Given this list of marker genes ABCC8, CDC73, IFNA14, KRR1, ATF2, GPLD1, CPB2, LORICRIN (loricrin cornified envelope precursor protein), FBXL4, PDE10A, CADM4, ZNF134, FZD5, SCN7A, GUCY2C, LTBP4, BCL2L11, PDE6A, BMP10, MASP2, CEP162 (NCBI Gene Id 22832), HTR1E, SYT5, MAP2, ZNF200, TANC2, PAX7, MON2, CCR3, NOS2 (nitric oxide synthase 2), EDIL3, PCM1, ZNF157, MLLT10, POLR1HASP, ATP8B1, GCM1, PART1, FSHR, TFDP2, P2RY10, KCNA5, KLRC4, KRT33A, PLPPR4, PHOX2B, NFAT5, PAX9, SLC4A3, EXOC4, TTTY1, KNG1, GLRA3, ERC2-IT1, ZP2, OCM, SIRPB1, S100A5, ATP4B, ZNF266, AQP7, IL7, KRT2, NRTN, CFH, RYR3, ABCB10, EPHB2, COLGALT2, ZSCAN26, GPR18, MYH2, GNG4, RUNX2, GPR19, FAS, GJB5, DMD, ADAM20, AOC4P, DNAJC16, SIM2, CRHR1, C1orf216, PVR, SLC15A1, MC5R, DRC3, TBX19, PTPRB, ZNF821, TMEM26, H3C6, GPR171, RORB, CAMK4, HNF1A, POLR2K, ABO, GLE1, DBT, PHLDB1, CXCL5, TENM4, RPS6KA5, RNF24 (NCBI Gene Id 51262), FGF18, POU6F2, CCL16, AMOT, PAXIP1, BRCA1, R3HCC1L, SLC17A3, SRPK3, SULT4A1, SLC4A8, IL11RA, DGCR5 (NCBI Gene Id 85356), PDE4D, RB1CC1, USP46, POU6F1, TBXT, COX6A2, ATP6V0A2, OR2B6, RREB1, PGM3, NR3C2, ERCC4, NTNG2, PSG1, ATXN3, AMMECR1, PCDHB17P, SIX6, ELAVL2, ATP2B2, ADAMTSL3, LECT2, MDM2, ARL3, RAD51D, TRIM24, TSSK2, STAC, CTRL, ZBTB14, RXRG, FOSL1, MAGEA9, SLC6A2, HOXD4, KRT34, FNTB (NCBI Gene Id 2342), SOAT2, SLC22A6, IGKV7-3, NRXN1, CD8A, BRINP3, SPA17, LGI1, NXPE3, GUCY2F, COL19A1, GNPAT, IL16, CYP2E1, PRELID3A, CYP11A1, COL8A1, CALN1 (calneuron 1), HCRTR2, PHF10, MSL3, SPATA2 (spermatogenesis associated 2), IPO9, SUPT3H, NR1I2, IVL, PLA2R1, SERPINA4, F2RL3, NPFF, here is a description of the gene set: Human Gene Set: MORF_BCL2L11 studied in species Homo sapiens Neighborhood of BCL2L11 Neighborhood of BCL2L11 BCL2-like 11 (apoptosis facilitator) in the MORF expression compendium